Given this list of marker genes SYT1, CRP, APOA5, AP2M1, LDLRAP1, SNX17, DNAJA1, APOB, HSP90B1, AP2A1, APOE, LRPAP1, LANCL1, HSPG2, APBB1, APBB3, PCSK9, CLU, CLTC, PICALM (NCBI Gene Id 8301), MESD, APP, DAB2, SACS, DKK1, ANKRA2, here is a description of the gene set: Human Gene Set: GOMF_LOW_DENSITY_LIPOPROTEIN_PARTICLE_RECEPTOR_BINDING Binding to a low-density lipoprotein receptor. species: Homo sapiens